Given this list of marker genes POLR1C, CRKL, EYA1, MAPK1, SF3B2, SIX1, POLR1D, KDM6A, WAC, SIN3A, KMT2D, POLR1B, BCR, PUF60, RPL10, TFAP2A, TCOF1, HNRNPK, SIX5, here is a description of the gene set: Congenital developmental defect arising from the primitive branchial apparatus. Human Gene Set: HP_BRANCHIAL_ANOMALY Branchial anomaly studied in species Homo sapiens